The following is a description of a gene set: We have determined that sustained expression of EBF suppresses alternate lineage genes independently of Pax5. Genes down-regulated in pro-B cells with PAX5 knockout: control versus over-expressing EBF1. species: Homo sapiens Human Gene Set: GSE9878_CTRL_VS_EBF_TRANSDUCED_PAX5_KO_PRO_BCELL_DN from publication Pongubala JM, Northrup DL, Lancki DW, Medina KL, Treiber T, Bertolino E, Thomas M, Grosschedl R, Allman D, Singh H (PMID 18176567), and this is the list of marker genes: ANG, SNN, MRPL46, ARHGAP11A, MAP3K4, TXNDC16, TMEM263, ENPP1, SAP130, TDP1, APPL1, ANKRD37, NDUFAF4, BDH1, BANK1, HDAC3, C15orf39, ADM (NCBI Gene Id 133), FANCD2, CCNE2, MRS2, HVCN1, NANS, BUB1, ZBTB11, DPAGT1, SLAMF6, CD82, GEMIN5, CD72, ECT2, SNIP1, USP42, SSR2, PIGR, CDC123, FAM174C, TRIAP1, PRC1, UBE2M, MTHFD1L, CCDC34, FAM3C, C2CD3, FZR1, ADA, ZFP64, LGR5, SUZ12, MTG1, ITCH, GCN1, TRAIP, OXNAD1, RNMT (RNA guanine-7 methyltransferase), EPRS1, TRNT1, HSPD1, NEK2, FCRLA, LHFPL6, ATRN, NKRF (NCBI Gene Id 55922), CBX1, SH2D2A, TMEM26, PTCD3, PIK3AP1, DHPS, AACS, ENPP6, TERT, AKAP1, CENPK, SCT, CIP2A, KIAA0930, DLEU7, YME1L1, RARS1, SACS, SLC29A1, RBM8A, IKZF1, PDE5A, SLFN12, KCNK6, GPD1L, FOXO1, RBM34 (NCBI Gene Id 23029), CIAO3, MAP3K1, TMEM183A, CCND3, URB2, NUP58, GPSM1, PDE3B, NR1D1, TMEM177, TMEM81, GARS1, NFYB, GRIK2, GK5, RIOK1, ELP4, YARS1, LY6D, ABCB6, THOC1, WDR62, ATP6V1E1, ARMC6, HSDL2, DBF4, TNFAIP1, APOOL, COQ7, PAIP1, SEC63, CTPS1, DDIAS, PPHLN1, DIPK2A, WDHD1, VPS13D, EIF2AK3, LAMC1, KIF18A, REM1, TIMM8B, ZNF428, ATAD5, CHCHD1, CD37, PLXND1, POLR3K, SRP19, PYGO2, ARHGAP19, GPSM2, POU2F1, ATL2, CENPH (centromere protein H), NLN, FDPS, NSD2, TOMM70, YPEL2, GRWD1, ADAM17, KIAA0040, CLDND1, CENPF, FASTKD5, ILF2, CDC25B, PDE2A, RAB35, AP1AR, CYP51A1, HCK, ENDOU, PREP, CD79B, KPNA4, ZNF518B, GBP6, WDR4, JADE3, MYCBP, POC1A, SAPCD1, COX11, BEND3, BRCA1, GSTCD, BOP1, UBE2L3, RRAS2, RAD51, GTF2H2, TPX2, BYSL, OAZ2, PCED1B, TMCC1, VAPA, WDR18, METTL1, MTHFD2, SRFBP1, CPSF2, KIF11, NUP107, PLEKHF2, DNAJC21, MIPEP, TIMM9